Given this list of marker genes Agrp, Nppa, Ucn3, Vgf, Adcyap1, Ecrg4, Pdyn, Nts, Nppc, Npvf, Ghrh, Pyy, Npff, Grp, Hcrt, Npy, Cck, Cartpt, Gal, Oxt, Vip, Prlh, a, Avp (arginine vasopressin), Ppy, Spx, Cort, Qrfp, Nmb, here is a description of the gene set: Mouse Gene Set: GOMF_NEUROPEPTIDE_ACTIVITY The receptor ligand activity of any polypeptide expressed in, and secreted from a neuron. studied in species Mus musculus